The following is a description of a gene set: studied in species Homo sapiens Human Gene Set: GOBP_ENDOCARDIAL_CUSHION_MORPHOGENESIS The process in which the anatomical structure of the endocardial cushion is generated and organized. The endocardial cushion is a specialized region of mesenchymal cells that will give rise to the heart septa and valves., and this is the list of marker genes: BMP7, TGFBR1, MSX1, RBPJ, BMP5, BMPR1A, TBX2, TGFB2, HEYL, SMAD4, DCHS1, MDM4, NOS3, HEY2, ROBO1, BMP4, TGFB1, MSX2, SNAI1, FGF8, GATA5, TBX20, MDM2, TWIST1, TBX3, SOX9, HEY1, NOTCH1, TGFB3, APC, APLNR, SMAD2, SNAI2, NOG, BMP2, TMEM100 (transmembrane protein 100), ROBO2, ADAMTS5, ACVR1, ACVRL1, ISL1, ENG, TGFBR2, CPLANE2